The following is a description of a gene set: Immune cell-specific expression is one indication of the importance of a gene's role in the immune response. In order to identify such patterns, we set out to broadly profile gene expression in a variety of immune cells. from publication Abbas AR, Baldwin D, Ma Y, Ouyang W, Gurney A, Martin F, Fong S, van Lookeren Campagne M, Godowski P, Williams PM, Chan AC, Clark HF (PMID 15789058) studied in species Homo sapiens Genes up-regulated in comparison of naive CD8 T cells versus naive B cells. Human Gene Set: GSE22886_CD8_TCELL_VS_BCELL_NAIVE_UP, and this is the list of marker genes: GBP2, APOL3, CD27, LRIG1, NMT2, EGLN2, LDLRAP1, TPST2, POLR1E (RNA polymerase I subunit E), PLEKHF1, XBP1, FYB1, NKG7, GRAP2, GBA1LP, ANXA1 (annexin A1), FMNL1, CCL5, PRKCA, STK39, MT2A, SVIL, IL17RA, CTSA, ZAP70, MCAT, TSPAN32, RTN3, MT1X (NCBI Gene Id 82523), BCR, S1PR4, NQO2, ENO2, CABIN1, STAU1, TACC3, IDH2, PTPN4, SLC25A44, TXN2, PKN1, TARP, NELL2, DUSP7, PTGER2, PRORP, RGS10, INPP4A, MYBL1, RAB27A, PVRIG, EEIG1, NIBAN1, ECPAS, PTPRA, ETHE1, MRPL12, UBASH3A, FXN, SLC35D2, PRKCQ, CCDC88C, INPP4B, APMAP, IL7R, FLT3LG, MPHOSPH9, NMRK1, CPT1A, ZBTB38, MRPL57, ATP2B4, SACS, CD247, RGCC, LRCH4, BCL11B (BCL11 transcription factor B), ATP13A2, ACTG1, FYCO1 (NCBI Gene Id 79687, FYVE and coiled-coil domain autophagy adaptor 1), NACC2, ITM2A, RORA, BAG3, SIGIRR, DENND1B, RRS1, TMED3, PGRMC2, ECHDC2, CD7, MATK, PCNT, FAM8A1, PA2G4, NHERF1, R3HDM1, CLTA, CDR2, DDX60, KLRB1, RHOC, MAL, KLHL21, H4C3, PXN, LIME1, EIF4G1, PLEKHB1, PLSCR3, IL32, DENND2D, CRTAM, ZYX, B4GALT3, TXK, PITPNC1, TIMP1, ITGAL, DEXI, GTF3C1, ABHD14A, IL27RA, NDFIP1, CERK, HMOX2, GALC, GZMA, HMG20B, FKBP5 (FKBP prolyl isomerase 5), TESK1, NDUFB7, LRFN3, CIAPIN1, IL2RB, KLRC3, GPR171, LGALS1, TRABD, RANGAP1, LEPROTL1, GZMM, XAB2, DGKZ, ZMYM6, APBB1IP, NOSIP, MAGED2, UBE3A, MED15, CYB561D2, RSL1D1, TIMM8B, PLAAT3, GNLY, GLT8D1, OPTN, JPT1, PRR5, LPIN1, PRMT2, ARRB2, NIPAL3, UAP1, LEF1, GBP1, MAP7D1, SAMSN1, CITED2, IFITM3, EFHD2, SMARCA2, MPHOSPH10, PRF1, GIMAP6, P4HB, AIFM1, COL6A2, MRPL17 (mitochondrial ribosomal protein L17), MVP, SF3A3, LTBP3, KCNAB2, MTX1 (NCBI Gene Id 4580), CD3G, PSMD1, RUNX1, CST7, KLRC4, NRBP1, UNC119B, CD2, CEP68, MOGS, THYN1, CTDP1, PLEKHB2, P4HTM, NUCB2